Given this list of marker genes KIF26B, CTNNB1, LIF, GDNF, PAX8, SIX2, WNT9B, GREM1, SALL1, LHX1 (LIM homeobox 1), PAX2, SMO, STAT1, here is a description of the gene set: species: Homo sapiens The process in which the anatomical structures of the metanephric renal vesicle are generated and organized. The renal vesicle is the primordial structure of the metanephric nephron epithelium, and is formed by the condensation of mesenchymal cells. Human Gene Set: GOBP_METANEPHRIC_RENAL_VESICLE_MORPHOGENESIS